The following is a description of a gene set: Human Gene Set: MANNE_COVID19_COMBINED_COHORT_VS_HEALTHY_DONOR_PLATELETS_UP species: Homo sapiens from publication Manne BK, Denorme F, Middleton EA, Portier I, Rowley JW, Stubben C, Petrey AC, Tolley ND, Guo L, Cody M, Weyrich AS, Yost CC, Rondina MT, Campbell RA (PMID 32573711) Thrombotic complications in patients with COVID-19 are common and contribute to organ failure and mortality. Patients with severe COVID-19 present with hemostatic abnormalities that mimic disseminated intravascular coagulopathy associated with sepsis with the major difference being increased risk of thrombosis rather than bleeding. However, whether SARS-CoV-2 infection alters platelet function to contribute to the pathophysiology of COVID-19 remains unknown. In this study, we report altered platelet gene expression and functional responses in patients infected with SARS-CoV-2. Strongly upregulated genes from differential gene expression analysis of platelets from 10 combined ICU and Non-ICU COVID-19 patients and, for comparison, 5 healthy donors, and this is the list of marker genes: COX10, HPSE, APLP1, ALS2CL, HMBS, PFDN2, MT1X, TBC1D22B, NPIPB15, LY6E, NAGLU, EFNA1, P2RX4, SMIM1, GYPC, NUDT14, FDXR, LINGO1, SRM, LRRC2, SERPINH1, TSPAN4, TPM2, LGALS3BP, HBA2, ALAS2, FAM131C, MMP17, KIFC2 (NCBI Gene Id 90990), TP53I3, MSRB2, NPW, CDCA7L, LYRM4, LBHD1, IRF7, JCHAIN, DDIT3, TSPAN17, HBA1, TEX10, CERCAM, PPP3CC, RSAD2, RNF144A, ARMC12, HERC6, IDUA, MAMDC4, LPAR2, PGPEP1, KEL, ACACA, PIK3IP1, KREMEN1, PPP6R2, GADD45G, TAPBP, LMO4, LPIN1, ADCK5, IFITM3, MINDY4, NXT1, HBB, DECR2, HLX, CMPK2 (cytidine/uridine monophosphate kinase 2), LRP3, FBXO32 (NCBI Gene Id 114907), RELB, MAOB, MAPRE3, HMGA1, FKBPL, EMID1, USP18, ALKBH3, CDHR1, CASZ1, HBE1, MRPL12, S100A10, PALS2, LY6G6F-LY6G6D (LY6G6F-LY6G6D readthrough), CMTM7, SLC25A39, VASN, FAM174C, UQCC5, ITPKC, NTAQ1, CLDND2, METRN (NCBI Gene Id 79006), PCYT2, TPRN, TATDN3, GCKR, ZBTB49, MGAT5B, IFITM2, WNT5B (Wnt family member 5B), PALM3, POR, CAMK2A, HRC, KLF1 (KLF transcription factor 1), FAM83H, UQCC3, EXOC3L4, WDR53, FNDC4, AHSP, CLN6, HBM, TBC1D3L, PLD6, MVB12A, DPM2, TXNRD3, FLYWCH1, MIIP, SPINK4, NRSN2, IFI6, ARL2, XAF1, FAM177B, CDH6, ASIC4, SEC14L2, JAK3, SLC6A8, INSL3, XYLT2, IFI27, PMF1-BGLAP, IFITM1, ARL3, CCDC24, ISG15, PSPN, SHISA4, CISH, NICOL1, OLFML2A, NKIRAS1, IGLL5, PARP12, CD3D, LTBR, CAPN12, HPR, RNF213, CRELD2, ORC5, MAPK12, NDUFS8, SLC2A1, AMHR2, PCGF2, TNFRSF18, ANKRD45, ZNF496, H2AC25, HBD, MZB1, EPB42, TGIF2, SELENBP1, NR1D1, NDRG3, SPATA20, SNX27, ZNF385B (NCBI Gene Id 151126), TMEM208, SLC25A37, COL18A1, MSANTD1